Given this list of marker genes Krt77, Krt81, Krt71, Flg, Krt2, Tuft1, Krt73, Krt74, Loricrin, Sprr2i, Krt7, Krt79, Krt90, Krt78, Krt76, Krt84, Krt86, Sprr2g, Krt10 (NCBI Gene Id 319382), Krt82, Pnpla1, Krt72, Krt80, Krt4, Krt85, Sprr2d, Krt75, Sprr1a, Krt36, Gm5478, Krt83, Krt87, Gm5414, Krt5, Sprr2e, Krt1, Krt6a, Krt6b, here is a description of the gene set: Mouse Gene Set: GOMF_STRUCTURAL_CONSTITUENT_OF_SKIN_EPIDERMIS species: Mus musculus The action of a molecule that contributes to the structural integrity of an epidermal cutaneous structure.